The following is a description of a gene set: Human Gene Set: GOMF_N_ACYLTRANSFERASE_ACTIVITY Catalysis of the transfer of an acyl group to a nitrogen atom on the acceptor molecule. studied in species Homo sapiens, and this is the list of marker genes: GLYATL3, BRD1 (NCBI Gene Id 29975), JADE1, TAF10, KAT8, BRPF3, ING3, PLAAT3, MCM3AP, SAT2, CERS6, HAT1, NAA10, TAF9, CERS4, NAT10 (N-acetyltransferase 10), NAA20, SRCAP, ABHD14B, CDY1B, BAZ1A, NAA50, NMT1, CERS5, BRCA2, USP22, KAT2B, PYGO2, NAT9, PLAAT1, KAT6A, KAT14, TLCD3B, GLYATL1, TGM2, CERS1, NCOA3, PLAAT4, TAF1L, NAA40, AANAT, CDY2B, NAT1, SMARCE1, ATF2, SATL1, CERS2, LIPT1, GTF3C4, ATAT1 (NCBI Gene Id 79969), KAT6B, ALAS2, HGSNAT, CDY2A, GTF2B, NAT8L, BAAT, NAP1L2, ESCO2, ESCO1, EP300, NAGS, MEAF6, NAT8, BRPF1, NAA11, NAT14, GLYATL1B, TADA2A, PLA2G4E, PHF10, GLYATL2, NCOA1, GLYAT, BLOC1S1, NAA30, CDY1, PLAAT2, KAT2A, NAA80, CLOCK, TAF1, TMEM68, NAT2, CERS3, KAT7, JADE2, PLAAT5, ARRB1, KAT5, GNPNAT1, NAT8B, ALAS1, SAT1, NMT2, CREBBP, NAA60, ING4